The following is a description of a gene set: species: Homo sapiens Human Gene Set: MIR372_3P Genes predicted to be targets of miRBase v22 microRNA hsa-miR-372-3p in miRDB v6.0 with MirTarget v4 prediction scores > 80 (high confidence targets). from publication Chen Y, Wang X (PMID 31504780), and this is the list of marker genes: KPNA2, KMT5B, PKHD1 (NCBI Gene Id 5314), RASGEF1A, TRIM36, TMEM100, SLC40A1, ZFYVE26 (zinc finger FYVE-type containing 26), FYCO1, MTF1, NFIB, PARP8, SYNC, SHCBP1, DNAI7, LEFTY2, PRDM8, E2F5, SSX2IP, GRM5, ALDH1L2, IKZF2, UNKL, GALNT3, ZNRF3, ARHGEF10, MTUS1, RTN1, SPRED1, MYLK, ST3GAL1, FAM168B, GPC6, ZNF827, TET2, HAUS8 (HAUS augmin like complex subunit 8), RASSF2, LYST, ZKSCAN1, CCNJ, MED12L, RELA, FGD5, ANKRD52, TMEM86A, ITGB8, LEFTY1, ZRANB1, TSHZ3, MKNK2, ITPRIPL2 (NCBI Gene Id 162073), MCL1, PPARA, TMUB2, ADAT2, SS18L1, QRSL1, MARCHF5 (NCBI Gene Id 54708), SUZ12, R3HDM1, ZBTB41, KAT2B, CROT, RAB11A, SLAIN2, ROCK2, CORO2B, GUCA1C, ATF6B, ELK4, POLQ, CYBRD1 (NCBI Gene Id 79901), SLC33A1, C2CD2, MYCN, ARHGEF17, TCAIM, SUCO, NHSL3, APOBEC4, CYP20A1, GDF11 (NCBI Gene Id 10546), CYB5D2, BCL6, KREMEN1, MYRF, GPCPD1, TBC1D2, SYDE1, ATAD2, TMEM170B, RYR2, CDC23, CFL2, APP, DNAJC27, CDCA7, H2AJ, PPP6C, CYP26B1, RPS6KA3, GPR6, PTGDR, RAB11FIP1, DENND5B, MFAP5, RFX3, UNC80, TSEN34, PHF14, LRP8, SNRK, KIF26B, LRP2, CUX2, PTPN21, MICA, FZD6, MSL1, TRAPPC14, CELF2, TANC1, SMNDC1, TNRC18, RB1CC1, C2orf69, SMARCC2, SERF1A, MBNL3, SPOP, ADAM9, PKD2, SNX8, CMTR2, DUSP2, MAN1A1, SUV39H1, REST, CNOT6, ERCC4, PHACTR4, DPP8, REEP3, RUBCN, CCSAP, HP1BP3, PDE8A, SLAIN1, SYTL4, ARID5B, RRAGD, IRF2BP2, TNKS2, TAGAP, SLC24A2, CXCL1, RSBN1, UBE2J1, CAPRIN2, DPYSL5, INO80D, LCOR, HECTD2, GLIS3, PAF1, PAK5, SRCIN1, NR4A3, PIGM, JPT1, LAMA3, TRIP11, BTG1, UBE2Q2 (ubiquitin conjugating enzyme E2 Q2), SDC1, FNDC3A, MIGA2, EXOC5, RELL1, ZNF362, IRF2, PHF12, EIF3M, TMTC2, DCAF6, BCL11A, CLIP4, USP24, GPM6A, ZC3H13, MPC1, USP46, SON, DYNC1LI2, LHX6, DCUN1D1, HDAC4, SAMD12, ARID4A, ZNF532, ZBTB7A, ARHGAP30, RORA, ANKRD13C, E2F7, SETBP1, LATS2, FGD4, VDR, AGO1, NFYA, PDE4D, SLC15A2 (solute carrier family 15 member 2), TBC1D8B (NCBI Gene Id 54885), LAMP5, DRD1, PRDM4, PAK2, ZNF367, FSTL5 (follistatin like 5), ZFX, FZD3, CREBRF, TMEM64, ASAP1, CPEB1, OXR1, PDIK1L, PTPRD, HIPK3, TET1, RUNX2, SPTLC2, KDM1B, LMO3, RNF216 (NCBI Gene Id 54476), VLDLR, MIXL1, GUCY1A1, NUFIP2, RAD18, TMEM123, CUX1, TRPV6, DCUN1D4, EPHA5, ZBTB11, RABGAP1, TP53INP1, TGFBR2, PRRG1, BLCAP, MAP3K2, RBL1, EZH1, TIPARP, RAB11FIP5, TIAM1, ABHD3, PLAGL2, HS2ST1, CYBB, GLCE, FMR1, ST7L, RSF1, ELAVL2, SLC22A23, TXNIP, RGMB, BCAP29, MCC, E2F2 (E2F transcription factor 2), AAK1, PLAG1, ANKRD17 (NCBI Gene Id 84177), SKIDA1, RGL1, MAPK9, ARMC8, PFKP, CREB5, GNPDA2, RAB22A, ZBTB33, TNFAIP1, DDHD1, HOOK3, OLFM3, HIF1AN, ZBTB5, TWF1, ZNF385A, ZNF75A, C6orf15, LHX8 (NCBI Gene Id 431707), AMER2, JAZF1, FRMD4A, EDNRB, NPAS3, MIER3, TAPT1, NFIA, ARID4B, BARX2, TET3, KIF3B, NR2C2, USP16, ANO6, MAP3K14, SERF1B (NCBI Gene Id 728492), MBD2, RNF6, FAT4, ASF1B, RBBP9, ISM2 (NCBI Gene Id 378772), ASF1A, MARCHF11 (membrane associated ring-CH-type finger 11), PHKA1, RAB5C, ZNF800, COG5, YOD1, PSD3, TFAP4, WDR37, ARL4C (NCBI Gene Id 10123), UBE2B